Given this list of marker genes Nubpl, Ndufaf6, Ndufb8, Ndufs8, Ndufaf7, Pyurf, Ndufa13, Ndufb1, Ndufa9, Ndufs7, Ndufs6, Ndufv3, Ndufs5, Ndufa10, Ndufaf4, Ecsit, Ndufaf5, Ndufa2, Ndufa12, Ndufv2, Ndufb10, Ndufa7, Tmem126b (transmembrane protein 126B), mt-Nd6, Ndufaf1, Ndufc1, Ndufb9, Ndufa5, Ndufs3, Ndufb3, mt-Nd3, Ndufaf3, here is a description of the gene set: part of: Respiratory electron transport This event has been computationally inferred from an event that has been demonstrated in another species.<p>The inference is based on the homology mapping from PANTHER. Briefly, reactions for which all involved PhysicalEntities (in input, output and catalyst) have a mapped orthologue/paralogue (for complexes at least 75% of components must have a mapping) are inferred to the other species. electronically inferred by orthology from the curated human pathway Reactome Pathway: Complex I biogenesis studied in species Mus musculus